Given this list of marker genes FGF13, ABHD3, MLLT10, NHLH2, KIF5B, CFTR, ZNF215, DLEU7, MAPK8, DAZAP1, KRTAP22-2 (NCBI Gene Id 100292523), CPEB4, ATP10D, HIBADH, GPR158, TNRC6B, BTRC (NCBI Gene Id 8945), DENND4C, CEACAM1, RBM7, LMLN, CNNM4, RCOR3, SIX4, USF3, NCK2, CBLB, CXCL8, NUP43, ATF2, PDGFB, KLHL29, FNBP1L, VPS50, RIT1, GALNT1, DOCK3, GOLGA3, MYO19, PARP8, DPYD, RPS6KA1, PRRC1, RSPO1, YARS2, MID1, DESI2, PIK3CA, RAP2A, SOX3, CNPPD1, PRKACA, IFNAR2, CASD1, EPAS1, SVOP, TRNT1, SEC14L1, SPAG9 (NCBI Gene Id 9043), CCDC138, COL4A1, EIF3J, EIF5A2, CHORDC1, CEP104, DCLK1, NPL, SIM1 (NCBI Gene Id 6492), UBE2R2, RAB21, SH3D19, CLOCK, NRBF2, NAV2, SUZ12, CSMD1, B3GALNT2, SCAMP5, PATZ1, CREBRF, SLC25A15, DPP9, ZNF561, CREB5, CADM1, LRRC59, PNPT1, MAPRE1, CNOT6L, DNAH5, ZC3H12C, HOOK1, FAM20B, here is a description of the gene set: from publication Chen Y, Wang X (PMID 31504780) Genes predicted to be targets of miRBase v22 microRNA hsa-miR-6732-3p in miRDB v6.0 with MirTarget v4 prediction scores > 80 (high confidence targets). species: Homo sapiens Human Gene Set: MIR6732_3P